Given this list of marker genes Csk, Pag1, Cd3e, Ptpn22, Cd3d, Ptprc, Lck, Cd3g, here is a description of the gene set: Reactome Pathway: Phosphorylation of CD3 and TCR zeta chains electronically inferred by orthology from the curated human pathway studied in species Mus musculus This event has been computationally inferred from an event that has been demonstrated in another species.<p>The inference is based on the homology mapping from PANTHER. Briefly, reactions for which all involved PhysicalEntities (in input, output and catalyst) have a mapped orthologue/paralogue (for complexes at least 75% of components must have a mapping) are inferred to the other species. part of: TCR signaling